The following is a description of a gene set: Mouse Gene Set: REACTOME_SYNTHESIS_OF_PIPS_AT_THE_PLASMA_MEMBRANE species: Mus musculus Synthesis of PIPs at the plasma membrane, and this is the list of marker genes: Inpp5j, Mtm1, Bmx, Pik3c2a, Pten, Pip5k1c, Pik3c2g, Plekha1, Pip5k1a, Mtmr6, Rab14 (NCBI Gene Id 99047), Mtmr1, Pi4k2a, Pik3r1, Inpp5k, Rufy1, Pik3cg, Ptpn13, Pik3r3, Arf1, Pip4k2a, Pik3cb (phosphatidylinositol-4,5-bisphosphate 3-kinase catalytic subunit beta), Inppl1, Pik3c2b, Plekha4, Plekha6, Pip4k2c, Inpp5d, Pip4k2b, Rab5a, Pi4k2b, Plekha5, Pik3r6 (NCBI Gene Id 432574), Mtmr3, Pik3cd, Pik3r5, Synj2, Pip5k1b, Plekha3, Pik3r2 (phosphoinositide-3-kinase regulatory subunit 2), Synj1, Plekha2, Mtmr14, Mtmr9, Pik3ca, Rab4a (RAB4A, member RAS oncogene family), Inpp4a (inositol polyphosphate-4-phosphatase, type I), Plekha8, Inpp4b, Ocrl